The following is a description of a gene set: This event has been computationally inferred from an event that has been demonstrated in another species.<p>The inference is based on the homology mapping from PANTHER. Briefly, reactions for which all involved PhysicalEntities (in input, output and catalyst) have a mapped orthologue/paralogue (for complexes at least 75% of components must have a mapping) are inferred to the other species. part of: Synthesis of substrates in N-glycan biosythesis electronically inferred by orthology from the curated human pathway Reactome Pathway: GDP-fucose biosynthesis studied in species Mus musculus, and this is the list of marker genes: Gfus, Fpgt, Fuom, Slc35c1